The following is a description of a gene set: Human Gene Set: MIR3189_5P Genes predicted to be targets of miRBase v22 microRNA hsa-miR-3189-5p in miRDB v6.0 with MirTarget v4 prediction scores > 80 (high confidence targets). from publication Chen Y, Wang X (PMID 31504780) studied in species Homo sapiens, and this is the list of marker genes: PTPRU, PTPRT (NCBI Gene Id 11122), FAM72C, RBM14, EZH1, NR3C2, TASP1, EDEM1, SLC35A3, FAM72B, CASQ1 (NCBI Gene Id 844, calsequestrin 1), FAM53A, TSHZ1, RIMS3, C1orf159, TRABD2B, MPPED2, CXXC4, REV3L, CTTNBP2, SORCS3, FAM72D, DYNC1LI2, FAM221B, MPZL1, CPSF7, TNFRSF10D, SBNO1, RNF187, ANKS1A (NCBI Gene Id 23294), SHOC2, DMRTC1B, FAM72A, TRIM5, BRD10, KALRN, DEFB132, B4GALNT1, SFMBT1, AIDA, PTGES3, TENM3, THAP1, BRD2, BORA, DMRTC1, RAG1, BTRC, ARID3B, TGFB3, TMEM104, IL6R, ARL6IP6, MTNAP1